The following is a description of a gene set: studied in species Homo sapiens Human Gene Set: GOMF_DYSTROGLYCAN_BINDING Binding to dystroglycan, a glycoprotein found in non-muscle tissues as well as in muscle tissues, often in association with dystrophin. The native dystroglycan cleaved into two non-covalently associated subunits, alpha (N-terminal) and beta (C-terminal)., and this is the list of marker genes: AGR3, PLEC, MAP2, CLASP1, AGR2, DMD, VCL, DAG1, AGRN, CLASP2, FKRP